The following is a description of a gene set: species: Mus musculus A process that directly activates any of the steps required for tolerance, a physiologic state in which the immune system does not react destructively against the components of an organism that harbors it or against antigens that are introduced to it. Mouse Gene Set: GOBP_TOLERANCE_INDUCTION, and this is the list of marker genes: Ccr4, Irak3, C3ar1, Acod1, Foxj1, Cd86, Nr5a2 (NCBI Gene Id 52226), Lilrb4b, Havcr2, Foxp3, Xkr8, Aire, Pdcd1, Hmgb1, Ido1, H2-T23, Lyn, Phlpp1, Itch (itchy, E3 ubiquitin protein ligase), H2-M3 (NCBI Gene Id 14991), Tnfaip3, Il2ra, Ccr7, Runx1, Cd3e, Icos, Cblb, Tgfb1 (transforming growth factor, beta 1), Marchf7, Tgfbr2, Lilrb4a